Given this list of marker genes Snai2, Rbpj, Spry1, Tgfbr2, Twist1, Snai1, Wnt2, Acvrl1, Msx2, Hey2, Olfm1, Notch1, Eng, Emp2, Wnt16, Smad4 (NCBI Gene Id 28063), Tgfbr3, Has2, Tbx3, Tgfb2, Fgf8 (fibroblast growth factor 8), Pdcd4, Tmem100, Adam15, Tgfb1, Msx1, Bmp2, Acvr1, Rtn4, Heyl, Bmp4, Tgfbr1, Nog, Hey1, Tgfb3, Efna1, Jag1, here is a description of the gene set: Mouse Gene Set: GOBP_CARDIAC_EPITHELIAL_TO_MESENCHYMAL_TRANSITION species: Mus musculus A transition where a cardiac epithelial cell loses apical/basolateral polarity, severs intercellular adhesive junctions, degrades basement membrane components and becomes a migratory mesenchymal cell.